Given this list of marker genes STAT1, CCL21, GRK5, FOXO3, CCL5, PRKCD, CCL24, GRK1, BRAF, PAK1 (p21 (RAC1) activated kinase 1), PTK2, PIK3R1, SHC3, CCL4, PRKX, PLCB3, CXCR3, GRK2, PIK3R2, GNGT2, GNG3, VAV3, CXCL11, CXCL14, NFKBIA, CCL28 (NCBI Gene Id 56477), CRKL, IKBKG, ADCY2, ADCY1, PRKCZ, CCR6, GNG4, PXN, PRKACG (protein kinase cAMP-activated catalytic subunit gamma), PRKACB, ADCY9, RAP1A, GNG8, CDC42, MAPK1, CCR2, CCR10, CCL27, PIK3R5, PIK3CA, GRK6, WASL, ELMO1, AKT2, GNAI2, CXCL13, STAT5B, PLCB2, ADCY7, GNG13, MAP2K1 (mitogen-activated protein kinase kinase 1), GNG5, GNB2, CCR9, CCL7, NCF1, CXCL16, ARRB1, CXCL9, BCAR1, GNB3, ADCY6, ROCK2, CXCL12 (C-X-C motif chemokine ligand 12), RAP1B, CCR4, PIK3R3, GRK4, GNB5, STAT3, PARD3, XCL1, PLCB1, GNGT1, CXCR2, CCL22, GNG10, ADCY4, GNG11, CRK, HCK, CCR7, CXCL10, KRAS, ITK, RAC1, CCL19, SHC1, CXCR5, PREX1, VAV2, GNB4, ROCK1, GNG12, RAC2, IKBKB, GNG7, CX3CR1, GSK3B, MAPK3, CX3CL1, CCL1, VAV1, CCR1, PIK3CB, CCL25, CXCR4, GRB2, CCR8, ARRB2, SHC4, PRKCB, PF4, CCR3, SOS1, GNG2, TIAM2, CCL20, CXCL3 (NCBI Gene Id 2921), SOS2, JAK3, CCL11, CCL15, XCR1, ADCY8, HRAS, CHUK, CXCL5, RELA, FGR, TIAM1, AKT1, GNAI3, PTK2B, CCL26, AKT3, PPBP, NRAS, GNB1 (G protein subunit beta 1), CCL17, DOCK2, CSK, JAK2, PLCB4, LYN, RASGRP2 (NCBI Gene Id 10235), WAS, ADCY3, CXCR6, RAF1, SHC2, CCL3, NFKBIB, PIK3CG, ADCY5, PIK3CD, NFKB1, STAT2, GNAI1, here is a description of the gene set: Chemokine signaling Human Gene Set: WP_CHEMOKINE_SIGNALING species: Homo sapiens